The following is a description of a gene set: species: Homo sapiens A change in state or activity of a cell (in terms of movement, secretion, enzyme production, gene expression, etc.) as a result of a thyroid hormone stimulus. Human Gene Set: GOBP_CELLULAR_RESPONSE_TO_THYROID_HORMONE_STIMULUS, and this is the list of marker genes: CTSH, RDX, BRD8, INHBB, MED1 (NCBI Gene Id 9327), GHSR, CTSS, THRB, CTSB, GCLM, GCLC, CTSL